Given this list of marker genes Tlr7 (NCBI Gene Id 170743), D1Pas1, Tasl, Ddx3x, Myd88, Slc15a4, Tlr8, here is a description of the gene set: The series of molecular signals initiated by a ligand binding to the endolysosomal toll-like receptor 8. Mouse Gene Set: GOBP_TOLL_LIKE_RECEPTOR_8_SIGNALING_PATHWAY studied in species Mus musculus